Given this list of marker genes IL1B, NLRP3, GLMN, PYCARD (PYD and CARD domain containing), CASP1, here is a description of the gene set: Shigella IpaH7.8 to NLRP3 Inflammasome signaling pathway. Pathway ID: N00948. Pathway type: Pathogen. Pathway class: nt06521 NLR signaling. studied in species Homo sapiens Pathway Definition from KEGG: IpaH7.8 -| GLMN -| (NLRP3+PYCARD) -> CASP1 -> IL1B Human Gene Set: KEGG_MEDICUS_PATHOGEN_SHIGELLA_IPAH7.8_TO_NLRP3_INFLAMMASOME_SIGNALING_PATHWAY